Given this list of marker genes Rab11a, Ndrg4, Pla2g3, Mtmr4, Eipr1, Inpp5f, Rab11b, Ehd1, Bves, Atp9a, Sorl1, Arhgap44, Rab11fip3, Actn2, Gripap1, Ehd2, Zdhhc2, Arhgap8, Commd1, Pla2g4e, Arhgap1, Akap5, here is a description of the gene set: Any process that modulates the frequency, rate or extent of endocytic recycling. species: Mus musculus Mouse Gene Set: GOBP_REGULATION_OF_ENDOCYTIC_RECYCLING